The following is a description of a gene set: from publication Chen Y, Wang X (PMID 31504780) studied in species Homo sapiens Human Gene Set: MIR2115_3P Genes predicted to be targets of miRBase v22 microRNA hsa-miR-2115-3p in miRDB v6.0 with MirTarget v4 prediction scores > 80 (high confidence targets)., and this is the list of marker genes: MTFR1, CLVS2 (NCBI Gene Id 387358), FGF5, IKZF2, NUP153, CPOX (NCBI Gene Id 201541), PCMTD1, PDCD2 (NCBI Gene Id 5134), C10orf71, CDC20B, SAP30L, GPR155, ALKBH8, TSPYL5, CLIC2, ZNF704, GSTA2, STRBP (spermatid perinuclear RNA binding protein), NEURL1B, GPM6A, NR4A2, TWSG1, DPP10, ACTR3, SYNJ2BP-COX16, RWDD1, ZFAND1, CTSO, CNTLN, ORC5, POLR2K, RC3H1, LIN54, MYF5, ANKS1B, TNFRSF21, MTCH1, DUSP10, ELF1, RHOA, SREK1, MSL2, CDS1, MAPK1, ERBB4, PMP22, CAMK2D, RAB3GAP1, FBXO7, ZNF529, HS2ST1, GCM2, MAP2, ENSA, TALDO1, CERS3, ZBTB6, SMC2, ZNF860, ARRDC3, ZNF638, SEL1L, GOLGA4, SND1, DNAJB2, CREG1, TWIST1, TNS3, PRKAG1, CCDC28A-AS1, RBBP9, ZMAT3, MEF2D, EIF4E3, BCAS1, FOXN2, RIMOC1, LRRC17, RAD23B, EYS, PRKCB (NCBI Gene Id 5579), ODF2L, CRY1, CXCL8, PDS5B, CPSF7, AARD, LCOR, PIK3CG, GPR176, ANO6, MTX3, PNMA2, POLR3G, PLP1 (NCBI Gene Id 5354), DAB2, ARFGEF2, TRAF3, ANKRD17, CIAO2A, RNF144A, MRS2, C6orf58, UGT2A3, P2RY14, TMEM33 (NCBI Gene Id 55161), ADGRG2, HACE1, RNF4, TRIM9, MEX3C (NCBI Gene Id 51320), RDH11, ANP32A, GAPT, ZSCAN32 (zinc finger and SCAN domain containing 32), C2orf78, KRTAP1-5, ELAVL2, PPM1D, SGPP1, PTPRE, ADAM28, PRICKLE2, RMND5A, LNPK, RNF11, CKS1B, RBM17, RIMKLB, TRAPPC2, SLCO6A1, PSMD5, OGN, BLMH, TET3, LCORL, SDCBP, BRD1, ALCAM, CAPNS2, LSM8, PCDH11Y, RECK, SORCS1, TKTL2, PTH, GTPBP10, EDIL3, MIF4GD, IL17RD, CASP14, KLHL11, TRPC6, CLDN22, CNBP, GAN, BTG1, TRPC5, TFAP2B, PABIR3, COX16, ATXN7, YAF2, WNT7A, ANKRD34B, ZNF507, ARCN1, RANBP17, TP63, RAB27B, LACTB, MINDY2, FAM120C, ZNF516, FUT9, MERTK, PABPC4L, CYP2U1, MECP2, EXD1, STARD5, DYNC1LI2, CCT4, USP24, ITGAV, ENDOD1, DEXI, AGL, GPC6, VEGFD, SDHAF4, GPATCH2L, ANKLE2, PDE8A, YIPF4, PEX13, DPY19L2, MAGOHB, TRAT1, RAB18, LETMD1, VEGFA, PROSER1, TBC1D31, RB1CC1, GSTA1, CAB39L, ODF2, RPS6KA6, ADSS2, ERCC6, DDX3X (DEAD-box helicase 3 X-linked), MTRR, SDHC, SH3TC2, AAK1, TOR1AIP2, VAMP3, GCSAM, FAM120B, CIP2A, HOOK1, RAC1, ZNF804A, SLMAP, EXO5, CDYL2, ARID2, ATG5, FADD, EXD2, MTMR4, PANX2, KBTBD8, SCAF8 (SR-related CTD associated factor 8), NEDD4